Given this list of marker genes CDK5, BRAF, RAP1A, RAP1BL, RAP1B, FMR1, SYT4, here is a description of the gene set: studied in species Homo sapiens Any process that stops, prevents or reduces the frequency, rate or extent of synaptic vesicle exocytosis. Human Gene Set: GOBP_NEGATIVE_REGULATION_OF_SYNAPTIC_VESICLE_EXOCYTOSIS